Given this list of marker genes WNK4, BMPR1B, ERBB4, STK36, NRK, DCLK1, IGF1R, MAP3K12, STK32B, ACVR1B, GAK, RET, ULK4, FGFR3, STK39, NEK11, NEK9, ERBB3, EPHA10, TBCK, IKBKB, here is a description of the gene set: species: Homo sapiens Human Gene Set: FINETTI_BREAST_CANCERS_KINOME_BLUE Breast cancer is a heterogeneous disease made of various molecular subtypes with different prognosis. However, evolution remains difficult to predict within some subtypes, such as luminal A, and treatment is not as adapted as it should be. Refinement of prognostic classification and identification of new therapeutic targets are needed. Using oligonucleotide microarrays, we profiled 227 breast cancers. We focused our analysis on two major breast cancer subtypes with opposite prognosis, luminal A (n = 80) and basal (n = 58), and on genes encoding protein kinases. Whole-kinome expression separated luminal A and basal tumors. The expression (measured by a kinase score) of genes encoding serine/threonine kinases involved in mitosis distinguished two subgroups of luminal A tumors: Aa, of good prognosis and Ab, of poor prognosis. This classification and its prognostic effect were validated in 276 luminal A cases from three independent series profiled across different microarray platforms. The classification outperformed the current prognostic factors in univariate and multivariate analyses in both training and validation sets. The luminal Ab subgroup, characterized by high mitotic activity compared with luminal Aa tumors, displayed clinical characteristics and a kinase score intermediate between the luminal Aa subgroup and the luminal B subtype, suggesting a continuum in luminal tumors. Some of the mitotic kinases of the signature represent therapeutic targets under investigation. The identification of luminal A cases of poor prognosis should help select appropriate treatment, whereas the identification of a relevant kinase set provides potential targets. from publication Finetti P, Cervera N, Charafe-Jauffret E, Chabannon C, Charpin C, Chaffanet M, Jacquemier J, Viens P, Birnbaum D, Bertucci F (PMID 18245477) Genes in the blue cluster of protein kinases distinguishing between luminal A and basal breast cancer subtypes.